The following is a description of a gene set: Catalysis of the hydrolysis of internal peptide bonds in a polypeptide chain by a mechanism in which the hydroxyl group of a threonine residue at the active center acts as a nucleophile. Human Gene Set: GOMF_THREONINE_TYPE_ENDOPEPTIDASE_ACTIVITY species: Homo sapiens, and this is the list of marker genes: PSMB9, PSMB6, PSMB10, TASP1, PSMB8, PSMB11, PSMB7, PSMB5, PRSS50